Given this list of marker genes Mgat5b, Pomt2, Pomt1, Dag1 (dystroglycan 1), here is a description of the gene set: Reactome Pathway: DAG1 core M2 glycosylations electronically inferred by orthology from the curated human pathway species: Mus musculus part of: DAG1 glycosylations This event has been computationally inferred from an event that has been demonstrated in another species.<p>The inference is based on the homology mapping from PANTHER. Briefly, reactions for which all involved PhysicalEntities (in input, output and catalyst) have a mapped orthologue/paralogue (for complexes at least 75% of components must have a mapping) are inferred to the other species.